Given this list of marker genes MAP2K6, TTLL6, XYLT2, CDR2L, SRP68, CHCT1, PITPNC1, ACTG1, OTOP2, ALYREF, SAP30BP, GNGT2, EFCAB3, SLC35B1, EXOC7, METRNL, CACNG1, ATP5MC1, TRIM47, ZACN, CCDC137, SECTM1, SMURF2, MYCBPAP, FADS6, PCTP, KAT7, PHB1, TRIM25, SLC38A10 (solute carrier family 38 member 10), FOXK2, MILR1, RPS6KB1 (ribosomal protein S6 kinase B1), TMEM104, CACNA1G, OTOP3, PPP1R27, LRRC37A3, SGCA, MKS1, PSMD12, COIL, KCTD2, TMEM94 (transmembrane protein 94), HOXB8, SKA2, BAIAP2, CHAD (chondroadherin), ENGASE, ABI3, PRKCA, LGALS3BP, SLC16A6, RPL38, ACOX1, BAHCC1, RPTOR, KCNJ16, C17orf67, BCAS3 (NCBI Gene Id 89751), RAB37, HOXB3, TLK2, HOXB9, NME1-NME2, UNC13D, CD300LF, LINC00469 (long intergenic non-protein coding RNA 469), COL1A1, ICAM2, GRB2, PPM1D, CANT1, HOXB13, CEP95, NAT9, DDX42, KIF2B, COPZ2, HOXB7 (NCBI Gene Id 3217), CSH2, SMG8, AFMID, MARCHF10, MMD, LUC7L3, TSPAN10 (NCBI Gene Id 83882), FAM20A, SLC16A3, RAB40B, BPTF, MIF4GD, FTSJ3, EPN3, CA10, UTS2R, ABCA6, MBTD1, CSHL1, DNAI2, CLTC, PDE6G, PECAM1, CSH1, TMEM105, RSAD1, RNFT1, FAM117A, HLF, GPR142, CD300E, RNF43, B3GNTL1, C17orf58, COX11, MRC2, LINC01973, WFIKKN2, SNF8 (NCBI Gene Id 95670), CCDC47, WIPI1, CASKIN2, METTL2A, ABCA8, PTRH2, NUP85, NGFR, SLC25A10, ERN1, HGS, GIP, TRIM65, DLX4, CEP131, NARF, GPRC5C, APOH, ATP5PD, RAC3, USH1G, GALR2, OXLD1, TRIM37, WDR45B, TSPOAP1, NDUFAF8, ANKRD40, TOM1L1, EVPL, TSEN54, NPLOC4 (NPL4 homolog, ubiquitin recognition factor), GH2, STRADA, LINC00482, EPX, CD300A, SAMD14, JPT1, FSCN2, UNK, BIRC5, DGKE, CSNK1D, SLC39A11, TIMP2, NOG, GNA13, NHERF1, OGFOD3, SCN4A, HOXB4, NME2, STXBP4, DCXR, SDK2, CALCOCO2, RNF157, CENPX, WBP2, POLG2, MRPL27, ARSG, TAC4, HOXB1, EME1, SPOP, SYNGR2, NOL11, CEP112, CHMP6, CDK5RAP3, TOB1, PNPO, C1QTNF1 (C1q and TNF related 1), SUPT4H1, NOTUM, USP36, CDK3, RAD51C, NACA2, MAP3K3, PPP1R9B, IGF2BP1, SOCS3, FOXJ1, UBE2Z, DLX3, GDPD1, MTNAP1, CD7, RECQL5, DUS1L, VMP1, HELZ, FAAP100, LINC02875, H3-3B, KCNJ2, YPEL2, TEX19, SCPEP1, SKAP1, PDK2, NFE2L1, HSF5, OR4D2, SNX11, RGS9, HOXB2, CACNG5, CACNG4, GGA3, PHOSPHO1, RFNG, ABCA10, MRPL58 (NCBI Gene Id 3396), SOX9, TTYH2, ZNF750, CCDC57, ITGA3 (NCBI Gene Id 4454), FDXR, ASPSCR1, AMZ2, HID1, HEXD, GPS1, HOXB5 (homeobox B5), AATK, LRRC59, TMEM100, TBCD, TK1, TNRC6C, PGS1, AXIN2, GALK1, TEX14, PRR15L (proline rich 15 like), MRPL12, PSMC5, KIF19, MRPS7, LIMD2, INTS2, NME1, SMARCD2, SEPTIN4, FN3KRP, NXPH3, FASN, COG1, TEPSIN, SPATA20 (NCBI Gene Id 64847), MRPL38, MED13, SSTR2, LPO, ZNF652, UTP18, CD79B, ANKFN1, BRIP1, CD300LB, HOXB6, CD300C, DDX5, PRR11, TUBD1, ACSF2, LRRC45, TBX4, ABCA9, APPBP2, MTMR4 (myotubularin related protein 4), CYBC1, CBX1, TMC8, NT5C, CDC42EP4, TEX2 (testis expressed 2), VCF1, TMC6, ABCC3, GRIN2C, ABCA5, PPM1E, SUMO2, LLGL2, CYTH1, TACO1, PRAC1, B4GALNT2 (NCBI Gene Id 124872), ARHGDIA (Rho GDP dissociation inhibitor alpha), HEATR6, MPO, FBF1, CA4, ITGB4, FN3K (NCBI Gene Id 64122), SP2, TMEM92, SPAG9, PRKAR1A, ARL16, SLC25A19, ARMC7, DHX40, USP32, SLC16A5, CD300LD-AS1, BTBD17, TBX2, GH1, here is a description of the gene set: studied in species Homo sapiens A single cancer cell contains large numbers of genetic alterations that in combination create the malignant phenotype. However, whether amplified and mutated genes form functional and physical interaction networks that could explain the selection for cells with combined alterations is unknown. To investigate this issue, we characterized copy number alterations in 191 breast tumors using dense single nucleotide polymorphism arrays and identified genes with copy number gain organized into 30 amplicons. Amplicons were distributed unequally throughout the genome. Each amplicon had distinct enrichment pattern in pathways, networks, and molecular functions, but genes within individual amplicons did not form coherent functional units. Genes in amplicons included all major tumorigenic pathways and were highly enriched in breast cancer-causative genes. In contrast, genes with somatic mutations in breast cancer were distributed randomly over the genome, did not represent a functionally cohesive gene set, and were relatively less enriched in breast cancer marker genes. Mutated and gained genes did not show statistically significant overlap but were highly synergistic in populating key tumorigenic pathways including transforming growth factor beta, WNT, fibroblast growth factor, and PIP3 signaling. In general, mutated genes were more frequently upstream of gained genes in transcription regulation signaling than vice versa, suggesting that mutated genes are mainly regulators, whereas gained genes are mostly regulated. ESR1 was the major transcription factor regulating amplified but not mutated genes. Our results support the hypothesis that multiple genetic events, including copy number gains and somatic mutations, are necessary for establishing the malignant cell phenotype. from publication Nikolsky Y, Sviridov E, Yao J, Dosymbekov D, Ustyansky V, Kaznacheev V, Dezso Z, Mulvey L, Macconaill LE, Winckler W, Serebryiskaya T, Nikolskaya T, Polyak K (PMID 19010930) Genes within amplicon 17q21-q25 identified in a copy number alterations study of 191 breast tumor samples. Human Gene Set: NIKOLSKY_BREAST_CANCER_17Q21_Q25_AMPLICON